Given this list of marker genes KY, CPEB2, PROX2, CCDC80, SH3GL3, C11orf86, RAB3C, ERBB4, EPPK1, PSD3, ZNF655, FZD3, P2RY1, KPNA1, SERTAD2, LPCAT1, SMAD4, SPRY1, HERC3, NAA30, C9orf153, PDE3B, SELENOT, RORA, CSF1, GPC6, ZNF800, MTR, MAGI2 (NCBI Gene Id 9863), PPP2R2D, BTBD3, PHYHIPL, TM9SF2, NR3C2, FBXO33 (NCBI Gene Id 254170), SLC4A4, EPB41, KLK12, STK38L, AXIN2, CADM1, ERBB3, QKI, CCNJ, VEGFA, AP1AR, ETFBKMT, CMTM4, GXYLT1, ENC1, ENPP4, AKAP11, YAP1, GPM6A, FRK, PTK7, LRP1, KDM4B, PPP1R15B, FOXF1, NIPSNAP3A, PABIR3 (PABIR family member 3), RTN3, SLC35B3, PTPRJ, LYSMD3, MARCKS, TBC1D26, RAB11FIP1, BICC1, NFAT5, SPANXN1, LIN9, AK4, SLC25A21, SGMS1 (NCBI Gene Id 93538), SEPTIN4, MTF1, HSF5, EEF1AKMT3, TNPO1, RPS6KA3, ZEB1, CLTC, LHFPL2, CALCRL, NOTCH2, RLIG1, JADE3, CPSF6, FAM114A2, ATP5MC3, CCNY, DSC2, ANKRD22, ROCK2, MINDY2, NECAP1, CCT8L2, GABRA4, PRKCE, ETNK1, JADE1 (jade family PHD finger 1), TNFAIP8, COX20, LRP6, SLC35A3, DCT, TP53BP2, NKD1 (NCBI Gene Id 85407), TOR1AIP2, RUNX2, NAA25, EXOC6B, ZIK1 (zinc finger protein interacting with K protein 1), VAPA, ZNF606, ADGRE2 (adhesion G protein-coupled receptor E2), PTPRM, LAMC1, BNIP5, MSI2, NACC2, DLG2, RBM47, SUSD1, TPR, MGRN1, RNF4, DUSP7, SPANXN5, ZFYVE16, CLDN11, RUVBL1, AFDN, SLC35A1, COL4A1, TAPT1, RHPN2, MORF4L2, B4GALT5, MICAL2, CHN1, SMAD1, PROX1 (prospero homeobox 1), GOLM2, SLC25A31, DHFR, SIPA1L1, CAMSAP2, GLYATL1 (NCBI Gene Id 92292), CDK14, MAGI1, HSPA8, RBPMS2, RBM41, TAOK1 (NCBI Gene Id 80214), CDK19, PJA2, EZR, CCDC141 (coiled-coil domain containing 141), CALU, MOSMO, PLCB1, TASL, CLOCK, NSF, E2F5, INPP4A, SORBS1, NFIB, SPINK13, ALAD, MTMR10, TBX3, SNRPF, MGA, AAK1, CFL2, INPPL1, DSC1, ZNF652, HSPA13, ACSL1, ZHX3, ANKRD50 (NCBI Gene Id 57182), DMXL2, MOB3B, LRRK2, ESRRG, SECISBP2L, AP1G1, ERRFI1 (NCBI Gene Id 54206), HSD17B11, TRAK2, HS3ST1, SLC19A2, LCOR, ZBTB20, AMOT, EVA1C, SLC30A8, CDH11, RAP2B, ABCD1, FBXO22, NEU1, AFF1, MAP3K13, PAX9, RCBTB1, KAT2B, VTI1B, ADAMTS9, SATB2, SCYL2, CCM2, MMD, KANSL3, STRBP (spermatid perinuclear RNA binding protein), EFNA2 (ephrin A2), CDC27 (NCBI Gene Id 996), PCNX1, SBF2, here is a description of the gene set: studied in species Homo sapiens from publication Chen Y, Wang X (PMID 31504780) Genes predicted to be targets of miRBase v22 microRNA hsa-miR-205-5p in miRDB v6.0 with MirTarget v4 prediction scores > 80 (high confidence targets). Human Gene Set: MIR205_5P